The following is a description of a gene set: Abnormality of the adrenal glands Abnormality of the adrenal glands, i.e., of the endocrine glands located at the top of the kindneys. species: Homo sapiens Human Gene Set: HP_ABNORMALITY_OF_THE_ADRENAL_GLANDS, and this is the list of marker genes: KCNJ11, MYT1L, CLCN2, BRAF, PDE11A, POLE, LHX4 (LIM homeobox 4), ZNRF3, MRPS25, WNK1, HSD17B4, TBX19, DPYSL5, TRAPPC11, RBM28, OCA2, PROP1, NNT, PEX13, IDH2, WNT4, SGPL1, PEX11B, TMEM127, GPR161, PEX3, CDKN2C, SDHC, POLR1D, LTBP4, TXNRD2, PEX16, IARS2, GK, CDH23, DHX37, NFKB2, CDKN1C, TBC1D24 (TBC1 domain family member 24), MAX, HESX1, KLHL3, MEN1 (NCBI Gene Id 4221), POR, CDKN2B, VANGL2, TBC1D7, MTHFR (NCBI Gene Id 4524), CYP11B2, ATRX, HYLS1, SRY, SCNN1A, ABCC6, ATP6V1B2, TNXB, WNT3, SNORD115-1, USP48, KRIT1, CHEK2, KDM1A, PEX6, CTNNB1, CDON, TBX1, CYP11A1, PEX12, PEX26, SDHA, ABCD1, NR3C2, ROBO1, CACNA1S, CYP17A1, KCNQ1, PRNP, CYP21A2, PEX14, MKRN3, ADH5, POLR1C, VAMP7, PDE8B, GATA4, NR3C1, NR0B1, ADA, CDKN1A, TERT, PWRN1, NF1, PRKACA, IGF2 (insulin like growth factor 2), APC, YY1, PWAR1, TCTN3, AAAS, PCSK1, WWOX, ENPP1, NSDHL, PIK3CA (phosphatidylinositol-4,5-bisphosphate 3-kinase catalytic subunit alpha), HTR1A, SAMD9, ANTXR2, RET, DLST, USP8, NFS1, MCM4, SCN4A, DNMT3A (DNA methyltransferase 3 alpha), GLI3, ESR1, SDHB, BCAP31, MDM2, PEX10, KANSL1 (KAT8 regulatory NSL complex subunit 1), HSD3B2, PLXND1, HERC2, SIX3, NKX2-6 (NK2 homeobox 6), BMP4 (bone morphogenetic protein 4), MRAP, LMNA, WNK4, PEX1, TCOF1, CACNA1D, PEX5, ZFPM2, GPR101, SNRPN, MAP3K1, KCNE3, SEMA3E, PRKAR1A, TP53, WT1, IDH1, KIF1B, VHL, GMPPA, PEX19, AIP, NDUFAF5, GNAS, NR5A1, VPS35L, HBB, LIPA, NDN, BCOR, STAR, NPAP1, SOX9, KCNQ1OT1, AIRE, MKS1, STEAP3 (NCBI Gene Id 55240), CYP11B1, POLR1B, WDR11, CILK1, POMC (proopiomelanocortin), MC2R, ZMPSTE24, SAA1, MAGEL2, SDHAF2, CHD7, SDHD (succinate dehydrogenase complex subunit D), PEX2, SNORD116-1, CDKN1B, MRPS7, CUL3, BTNL2, PTEN, KCNJ5, PDCD10, MDH2, CCM2, EPAS1, PROKR2, HLA-DRB1, WASHC5, TBCK, SLC25A11, CCDC22, CDKN2A (NCBI Gene Id 1029), NUAK2, CCND1, ARMC5, FH